The following is a description of a gene set: studied in species Homo sapiens TP53 regulates transcription of additional cell cycle genes whose exact role in the p53 pathway remain uncertain Human Gene Set: REACTOME_TP53_REGULATES_TRANSCRIPTION_OF_ADDITIONAL_CELL_CYCLE_GENES_WHOSE_EXACT_ROLE_IN_THE_P53_PATHWAY_REMAIN_UNCERTAIN, and this is the list of marker genes: CNOT1, CNOT11, PLK2, BTG2, NPM1, CNOT7, CNOT10, CNOT6L, CENPJ, CNOT6, CNOT9, TP53, CNOT8, TNKS1BP1, CNOT3, CNOT2, RGCC, PLAGL1, PLK3, CDC25C, CNOT4